Given this list of marker genes CIAO2B, PHLDB2, GATAD1, SH3TC2, PSMD10, TGFBR3, OCRL, FRMD6, CRYBG2, ELL2, NDRG4, SH2D5, PTGES, S100A6, HNRNPDL, AHNAK2, FSTL3, SIRT5, RAB42, PIAS3, OBSCN, CFAP251, IL4R, SPTSSA, NAPG, MAP3K6, MIR1915HG, APEH, EFR3B, FGF18, WNT6, MOB3B, ECT2, STING1, DPYSL2, TMEM177, MICAL2, SLC25A37, DHRS2, MAOA, AP3S2, KIF3A, STK17A, PLEKHJ1, RAP2A, POLR2K, TAOK3, MAFB, ARID3B (NCBI Gene Id 10620), NEU1, REPS2, S100A4 (S100 calcium binding protein A4), ZNHIT3, STXBP6, GLRX, IFI44, BMAL2, IGFN1, USP22, TINCR, MPP1, CD47, SPANXD, PBX3, FBLIM1, SLC5A6, B4GALT5, RTF1, DIAPH3 (diaphanous related formin 3), MYO5B, NFIB, SLC35F3, S100A16, CASK, PPOX, CCDC6 (coiled-coil domain containing 6), NEDD4L, PTPN12, FN1, NUDT22, PM20D2, IDS, WTAP, FN3KRP, KLF6, MICALL2 (MICAL like 2), EBI3, USP14, MST1R, NSF, FERRY3, UBR1, TSPAN6, CMTM6, PPP1R3F, DNAAF5, ELMOD2, PTGER4, ELOVL7, VAMP8, TMEM190, CDCA7L, SEH1L (SEH1 like nucleoporin), KRT80, FAM25A, CIB1, SUDS3, HIVEP2, COX8A, PTRH1, TNS4, HS2ST1, DOK7, TST, CAPG, TAF7, IFFO1, RPS14, TDG, TBC1D13, LY6K, SNHG12, MZT1, MMGT1, IFIT3, EID1, LDAF1, SLC30A1, HDAC4, CNOT6, GJB5, ARF4, PROCR, FKBP11, GPAT3, PHF8, COQ10A, LRRC75A, DIO2, FER, SCARA3, CELF4, ACTR1A, FAM168B, TRIM4, SYNC, RABGAP1L, TMEM183A, BICC1, ARPC1A, TIMP3, TRIM8, TMT1A, CSTF3, ATP11A, OASL, ZMIZ2 (zinc finger MIZ-type containing 2), GATAD2A, RAP1GDS1, POGLUT2, DHX58, CHP1, C2CD2, RFTN1, RP2, CARD19, TVP23C, OCEL1, RILP, TMEM158, DENND2A, RASSF7, DPYSL5, NAV2, LYPD3, MAP3K2, CILK1, RAB7B, CHKA, RAB2A, VSIG10 (NCBI Gene Id 54621), EFHC1, STAMBPL1, CELF1, BAIAP2L2, EFCAB11, PAQR6, KIAA2013 (NCBI Gene Id 90231), SPINT2, KIF1C, BIRC3, MYO18A, FCHO2, UBTD1, MGRN1, SLX1A, MRFAP1, HYAL1 (hyaluronidase 1), UNC13D, CD82, GPR39, DCAF11, LPCAT1, SPANXA1, RAP1B, ADGRA2, HSPA6 (heat shock protein family A (Hsp70) member 6), C14orf119, MFAP3, GNL1, GCA, TATDN3, PHLDA1, INF2, DCTN5, SUSD2, PAMR1, TNNC1, ISG20, BRD3OS, LYSET, KRT19, SNRPA1, ERC1, NDFIP2 (NCBI Gene Id 54602), BCAT1, ENY2, FAM174A, DARS1, TNFRSF8, MRPS27, LMCD1, GGACT (NCBI Gene Id 87769), TMEM164 (transmembrane protein 164), EGLN1, OLFML2A, COL6A1, THBS3, SOAT1, AP1S2 (NCBI Gene Id 8905), IFIH1, HMGCS1, SSH3, AQP1, OSBP2, RBM28, HRK, MTMR11, DEF8, IL6, CHCHD7, PLEKHM1 (pleckstrin homology and RUN domain containing M1), DPY19L1, GNAQ, SSR1, PCMTD2 (NCBI Gene Id 55251), PLEKHG2, RPL22, GABARAP, SYT17, ABCG2, PLEKHO2, EFL1, NAP1L1, AP4E1, EIF4G3, KIF1B, TACC2, RIPK4, SPSB2, VPS37A, CAV1, DKK1, DPH3P1, ILK, PLEKHA3, FSD1, HMGN4, ISG15, CALHM3, BAD, ADRA1B, SLC7A7, RGS3, GBP3, PPP1R18, PNMA1, ANXA8L1, SDCBP, DNAJC18, PTGS1, ZC3HAV1L, FAM111A, ATP6V0A4, RELB, PLEKHB2, SPIN2B, CORO2A, YOD1, GRB2, TMA16, SNX12 (sorting nexin 12), FANCL, ASL, MPLKIP, F11R, RIGI, NUP155, CXADR, MBNL1, CAMK2N1, ITGA3, SPOCK2, GDE1, MAP3K12, ITGB4, SFN, ERLIN1, AKAP12, TEX261, CDYL2, ARL1, TSPYL1, POLR3H, UTP3, FBXO42, IFIT2, LINC00165, STAMBP, PIGK, PTBP3, ARB2A (ARB2 cotranscriptional regulator A), ITPRIPL2, KLHL9, PHLPP2, SLC25A29, ZHX3, CANX, HR, SMC1A, MEGF8, SLC6A6, VPS35, TAX1BP3, FBXL3, NEDD4, TRAM2, SLC22A15, SRSF1, SPEG (striated muscle enriched protein kinase), PDPK1, CEACAM1, ELMO2, IFI27L1, S100A3, DHRS1, ERCC6L2, EIF1AX (NCBI Gene Id 83754), MSH3, UROD, TTYH3, SUPT4H1, OXCT1, C3orf18, GFM2, GNA12, PCLAF, TMEM64, MTCL1, ATG16L2, PSCA, C20orf141, ZNF655, PEA15, ZBTB4 (NCBI Gene Id 57659), ANKRD2, PTS, ENTREP1 (endosomal transmembrane epsin interactor 1), USB1 (NCBI Gene Id 79650), PDCL, POLDIP2, PRRG1, TMEM92 (NCBI Gene Id 162461), HK1, TSPAN14, SPARC, TBL1XR1, CPEB4 (NCBI Gene Id 80315), ANAPC13, UBL3, SNX29, DCAF7, ITGB8, FGF13, CHSY1, IFIT1, LAMB2, KRT15, PEDS1-UBE2V1, TNFSF13, TRIQK, PCGF5, DENND1A, PEX19, SPIN1, TMBIM1, DCTN4, CCSER2, PNRC2, ITPK1, PI4K2B, CLN5, KCNN4, RRAGA, GFPT1, VPS13A, CDV3, SEMA3B, TMEM25, BLCAP, ARHGEF28, CATSPER1, KDSR, RWDD4, EHD2, CCNDBP1, VDR, IER3IP1, CYB5R2, CCDC9B, MAPK1IP1L, EDN1, TACC1, RGMB, PRKCA, METTL9, DLG5, SLC27A1, BTBD1, CDH16, COL5A3, OAT, OSBPL3, AIDAP2, AGPAT3, KCTD17, ZMYND11, DPH5, APH1A, TECPR1, AHNAK, MATN2, TOGARAM2, STRA6, BAIAP2, LAMC2, IGFBP7, SLC9A6, FBN1, PPM1N, LSS, SLC31A1 (NCBI Gene Id 1317), DHRS11, RAB31, MAP7D1, SPC24, CCDC85C, CD24, HMGN2P46, OPHN1, DYNC2H1, CGGBP1, TUFT1, SLC12A4, RAE1, TPK1, CTSS, TRIM29 (NCBI Gene Id 23650), SMYD3, TGM1, EML1, DNAJB6, ALPP, ARPP19, ZC3HAV1, HEMK1, ERGIC1, CTNND1, FIGNL1 (fidgetin like 1), KRT34, BTBD10, GPSM1, PLEKHG4, SIN3B, AOX1, TNIP1, YRDC, TENT2, B3GNT3, PLA2G3, SLC39A13, DCTD (NCBI Gene Id 1635), DPH3, TNFRSF21, DKK3, HEG1, TMEM50B, RRAGC, EIF1AY, LIMK2, CALM1, KIF3C, WIPI1, LRP12, OPTN, TVP23B, IDH3A, HIPK1, UBE2D1, CREBL2, CHCHD10, PLS1, SLC7A6, GDPD5 (glycerophosphodiester phosphodiesterase domain containing 5), H1-0, EXT1, TMEM191A, FSTL1, TMEM248, MFSD3, LAT2, GBE1, CCL5, SPANXB1, HACD3, MEOX1, TCP11L1, RASL10A, SELENOS, TRNP1, PAFAH1B2, AGPAT1, DPAGT1, PTGR1, C3orf52, TMEM40, GMFB, GSTM4, DYSF, CEMIP2, MRFAP1L1, FBXO21, MTPN, CCNL2, PHOSPHO2 (phosphatase, orphan 2), SYNPO, SPON2, EPB41L1 (NCBI Gene Id 23260), UHMK1, LGALSL, PLEK2, TMEM184B, AFF4, PXN, TUBB, SCRN1, RAC2, MMS22L, ZNF318, MARVELD1, NRBP2, ILRUN, NFE2L3, MAN1A2, CCND3, SC5D, ACSS2, CD59, RTL8A, GJB3, CUL4B, PRSS23, IGFBP6, PKP4, RETREG1, EMP1, ST6GAL1, NCF2, CHMP1B, FITM2, ABI2, VASH1, BPNT2, IFT25, ARNT2, ROM1, PAK6, CHMP3, STARD7, ZBTB47, MOB4, RPL27A, RANGRF (NCBI Gene Id 51536), MAGEF1, TINAGL1, PDZK1, NFE2, SQOR, CHST14, NXT2, RAB1A, SENP7, SETBP1, RAB8B, GNB4, TMEM60, PIGF, RTL8C, PPP2R1B, TMPRSS5, NUFIP2, PRRC2B, ADCY9, PRRT3, INHBB, RRAD, LINC00667, KCTD2, HEXIM1, MTMR9, KAT2B, TNNT1, NFIA, SLC22A18, POLE3, SPIN4, MAPRE1, AMMECR1, GULP1, IL11, MROH6, NT5E, PGM2, SAMD9, ANKFY1, MGLL, MYEOV, GTF3C4, MAPKBP1, KAT14, BCAR1, CAST, LYPLA2P1, XPR1, YIF1B, ABL2, JAK3, FZD2, OPA3, ANKRD13A, RIMBP3, TENT5B, RIC8A, PRSS21, SKA2, AGPAT4, PLCB4, NF2, VAPA, PIP4P2, PPP2R2B, NAA30, TRMT5, LGALS1, HS1BP3, RABGAP1, DCP2, DUSP18, HMGN2, THSD4, PLEKHA6, SFXN3, TNXB, COL16A1, PHTF1, PPP1CB (NCBI Gene Id 5500), NSMCE4A, TRAF1, SKP1 (NCBI Gene Id 6500), SCD, MYO9A, TMEM139, ACAT2, CTNNAL1, FUT8, TMEM263, FLNB, EHD1, TMED8, PFKFB4, RFC1, TNK2 (NCBI Gene Id 10188), ENO2 (NCBI Gene Id 2026), USF3, RPRD1A, ULK2, KIRREL1, MUC1, ZBED5, TPD52, EID2, ELOA, ST6GALNAC2, MVP, PLEKHA7, UQCC1, GNB1, ZC2HC1A, MTDH, SOWAHC, XPA, GTPBP3, TGFBR1, RMI2, SQLE, SERTAD4-AS1, NPIPB1P, HNRNPR, MTA3, RNF169, LINC00205, C9orf40, FGFBP1 (fibroblast growth factor binding protein 1), NFKBIE, STK39, VWF, MYLK, NME7, ALDH16A1, FAHD1, CGN, SSC4D, KCNQ1, HMGN2P4, COL4A6, CSTF2T, ABCB10, IMPA1, CD9, LCOR, OAZ2, NAP1L5, FANCD2, SF3B5 (NCBI Gene Id 83443), WDR54, ARHGAP1, ROR1, TOM1L2, PBX1, BAK1, TLR4, AXL, PLEC, DIMT1, BTRC, MOB3C, STX16, EIF5A2, SF3B3, P2RY2, KCTD11, PPP1R12A, PCNX2, LAMB3, CLASP2, AASDHPPT, BCL2L1, DCAF6, ARHGDIB, JUN, TRIM63, ASRGL1, here is a description of the gene set: species: Homo sapiens Human Gene Set: FORTSCHEGGER_PHF8_TARGETS_DN from publication Fortschegger K, de Graaf P, Outchkourov NS, van Schaik FM, Timmers HT, Shiekhattar R (PMID 20421419) Mutations in PHF8 are associated with X-linked mental retardation and cleft lip/cleft palate. PHF8 contains a plant homeodomain (PHD) in its N terminus and is a member of a family of JmjC domain-containing proteins. While PHDs can act as methyl lysine recognition motifs, JmjC domains can catalyze lysine demethylation. Here, we show that PHF8 is a histone demethylase that removes repressive histone H3 dimethyl lysine 9 marks. Our biochemical analysis revealed specific association of the PHF8 PHD with histone H3 trimethylated at lysine 4 (H3K4me3). Chromatin immunoprecipitation followed by high-throughput sequencing indicated that PHF8 is enriched at the transcription start sites of many active or poised genes, mirroring the presence of RNA polymerase II (RNAPII) and of H3K4me3-bearing nucleosomes. We show that PHF8 can act as a transcriptional coactivator and that its activation function largely depends on binding of the PHD to H3K4me3. Furthermore, we present evidence for direct interaction of PHF8 with the C-terminal domain of RNAPII. Importantly, a PHF8 disease mutant was defective in demethylation and in coactivation. This is the first demonstration of a chromatin-modifying enzyme that is globally recruited to promoters through its association with H3K4me3 and RNAPII. Genes down-regulated in HeLa cells (cervical carcinoma) upon knockdown of PHF8 by RNAi.